Given this list of marker genes NPRL3, PRKD1, BNIP3, PLK3, CDK5RAP3 (NCBI Gene Id 92989), CSNK2A1, TICAM1, SVIP, NOD2, RALB, PIK3C2A, KAT5, MEFV, TRIM8, LACRT, HTT, HIF1A, AMBRA1, ZC3H12A, FOXO3, SLC35D3, SIRT1, TRIM65, TRIM32, PAFAH1B2, DEPTOR, STK11, SESN1, WIPI1, TRIM23, HMGB1, SLC25A4, WDR45, RUFY4, DELE1, CAMKK2, SLC25A5, MTDH, ATP5IF1, SNX30, PRKAA2, ULK1, SPTLC2, FBXO7, BAG3, GPSM1, IRGM, NOD1 (NCBI Gene Id 10392), HK2 (hexokinase 2), LRSAM1, STING1, PRKN, MOAP1, MAP3K7, TRIM13, SNX4, NPRL2, CDK16, HSPB8, MID2, PIP4K2A (phosphatidylinositol-5-phosphate 4-kinase type 2 alpha), GNAI3, ATG101, GSK3A, VDAC1, TMEM59, UBR4, SETD2, ATG2A, SNX7, ORMDL3 (NCBI Gene Id 94103), PARK7, SH3BP4, PIP4K2C, FYCO1, HDAC6, DCN, XBP1, SUPT5H, CERS1, FLCN, GSK3B, ELAVL1, DHRSX, TRIM22, MAPK3, PIM2, SNX18, MAP2K1, ATG5, TBK1, PIP4K2B, BNIP3L, LRRK2, RAB3GAP1, PIK3CB, TLR9, HUWE1, EPM2A (EPM2A glucan phosphatase, laforin, NCBI Gene Id 7957), SQSTM1 (NCBI Gene Id 94002), IKBKG, ADRB2, RB1CC1, ENDOG, ATG16L1, TOMM7, RNF152, C9orf72, CCNY (cyclin Y), SPTLC1, SH3GLB1, KDR, EIF2AK1, SESN2, FOXO1, PLK2, TSC2, MUL1, UFL1, SESN3, RNF31, RIPK2, IL4, IFNB1 (NCBI Gene Id 3456), TP53INP1, BECN1, TRIM21, ATF6, ATG13, RAB37, VPS13D, PINK1, WDR24, TFEB, ZDHHC19, CALCOCO2, UBE2A, GBA1, UVRAG (NCBI Gene Id 7405), SCOC, ROCK1, TOM1, LARP1, IRGQ, ELAPOR1, STUB1, BAD, USP20, RAB3GAP2, RPGR, DEPDC5, PLEKHF1, TPCN1, DAPK1 (NCBI Gene Id 1612), PRKAA1, OPTN, IFNG, HMOX1, CDC37, WAC, DDRGK1, SMCR8, here is a description of the gene set: Any process that activates, maintains or increases the rate of autophagy. Autophagy is the process in which cells digest parts of their own cytoplasm. species: Homo sapiens Human Gene Set: GOBP_POSITIVE_REGULATION_OF_AUTOPHAGY